Given this list of marker genes MED21, ATP6V1A, NEDD9, USP16, SNAPC3, GUCY2C, NAA11, RNF19B, STAC2, RABEP1, MADCAM1, RUNDC3A, JAG1, EREG, TMEM132A, DLST, MTMR7, SPRY1, RYR1, PFKFB1, MECOM, DMBT1, SPATA13 (NCBI Gene Id 221178), TLR2, RRS1, PLAT (NCBI Gene Id 5327), CHIC2, RPS6KA2, CYBRD1, CEMIP2, HLA-G, PTGR3, PDGFB, EFS, DNASE1L2, PLA2G4A, DHRS1, TRIB1, KLF7, TLR7, FOSB, TAF7, TMC2, NPY4R, SGMS1, ICOSLG (NCBI Gene Id 23308), FPR1, ZFP36, DOCK8, FHL1, HERPUD1, LCP2, CEP104, GTF2B, DPEP3, BMP6, ADORA2A, GATA2, SPRR3, CISH, IL10RA, COL4A5, ETV3 (NCBI Gene Id 2117), SNX12, RNF111, SPPL3, PI16, UBE2A, TMCC2, CADPS, AP1G1, TFF1, TREM1, LTV1, IL7R, CRLF2, SYNPO2, KIF11 (NCBI Gene Id 3832), RTBDN, USP13, DHX38, NCOA2, ITGAX, NRROS, HDAC5, BLNK, SHROOM3, SBDS, CRELD1, LMBRD1, SLFN12L, SYNGR4, TNIP1, CCL2, AFF4, GPR3, PDE4B, TAMALIN, VEGFA, ADSS2, SLC9A8, IL17D, ERRFI1 (NCBI Gene Id 54206), CD274, KCNA3, ACTN4, PIM3, RNF19A, USP9Y, ST3GAL1, BRD2, CEBPB (NCBI Gene Id 90277), SMARCA4, ZAN, CHKA, EPHA2, DNAJB11, PRIM2, CSMD1, CIDEB, SLC25A25, TMLHE, UBE2Z, SLC23A2, SYK, ADM, CCDC186, NCK2, CXCL6, CSTF3, VPREB3, GHR, BIRC3, RND3, GPNMB, CDC42EP3, JAK1, RFX1, RASGRP1, MATK, ITPRID2, HCAR2, GABRB2, FHOD3, ADCY8, PFKP, PGAP4, TOP1, DMP1, FCGR2B, ICAM1, RELL1, LRRC4, CHD1 (NCBI Gene Id 1105), UBA1, TMEM39A, YES1, ARIH2, HIP1R, TPR, KRT84, ETS2, SLC15A2, GSPT1, STARD4, ATP5PF, DNAJC24, TP53INP2, KAT6A, CBX4, UBE2J2, RIPK2, PIM1, CNTNAP2, TGM2, MET, TNFRSF1B, SDC1, FAM98A, SLC41A1 (solute carrier family 41 member 1), MMP14, PLEKHO2, NLRP3, ANAPC11, SLC12A1, MCOLN2, PABIR1, INTS12, RAP1B, CLEC4D, MARCKSL1, PKP2, DLD, LDLR, PDLIM1 (PDZ and LIM domain 1), CCL13, NUS1, IL12A, TIPARP, SOX2, here is a description of the gene set: Genes down-regulated in comparison of dendritic cells (DC) stimulated with poly(I:C) (TLR3 agonist) at 1 h versus DC cells stimulated with Pam3Csk4 (TLR1/2 agonist) at 1 h. mouse primary BMDCs were stimulated with tlr ligands and gene expression changes were profiled on Affymetrix arrays Human Gene Set: GSE17721_POLYIC_VS_PAM3CSK4_1H_BMDC_DN from publication Amit I, Garber M, Chevrier N, Leite AP, Donner Y, Eisenhaure T, Guttman M, Grenier JK, Li W, Zuk O, Schubert LA, Birditt B, Shay T, Goren A, Zhang X, Smith Z, Deering R, McDonald RC, Cabili M, Bernstein BE, Rinn JL, Meissner A, Root DE, Hacohen N, Regev A (PMID 19729616) species: Homo sapiens